The following is a description of a gene set: from publication Gavish A, Tyler M, Greenwald AC, Hoefflin R, Simkin D, Tschernichovsky R, Galili Darnell N, Somech E, Barbolin C, Antman T, Kovarsky D, Barrett T, Gonzalez Castro LN, Halder D, Chanoch-Myers R, Laffy J, Mints M, Wider A, Tal R, Spitzer A, Hara T, Raitses-Gurevich M, Stossel C, Golan T, Tirosh A, Suvà ML, Puram SV, Tirosh I (PMID 37258682) Genes upregulated in subsets of cells of a given type within various tumors In this study, an extensive analysis was conducted to define meta-programs (MPs) capturing intra-tumor heterogeneity across a spectrum of tumor types. The approach utilized non-negative matrix factorization (NMF) to analyze each cell type separately within individual tumor samples. This involved the analysis of malignant cells, macrophages, fibroblasts, endothelial cells, epithelial cells, T-cells, and B-cells. NMF was executed with varying parameter values (K=4, 5, 6, 7, 8, 9), thereby generating 39 programs for each cell type per sample. Each NMF program was summarized by the top genes based on NMF coefficients.\nRobust MPs were then delineated for each cell type using a set of stringent criteria, including recurrence within the same tumor, similarity to programs in other tumors, and non-redundancy within a tumor. Subsequently, these robust NMF programs were clustered (per cell type) based on Jaccard similarity, leading to the identification of MPs associated with each cell type.\nTo enhance the quality of the MPs, a refinement steps were undertaken, involving the removal of MPs suspected of reflecting low-quality data (with an overrepresentation of ribosomal proteins or mitochondrial-encoded genes), single-study inclusion, or similarity to miss-annotated cell types. Human Gene Set: GAVISH_3CA_METAPROGRAM_FIBROBLASTS_CAF_8 species: Homo sapiens, and this is the list of marker genes: ANO1, F2R, CLDN11, MMP28, CRIM1, ITGB5, ENG, NTM, SEMA3C, HAND2-AS1, ELN, CDKN2B (NCBI Gene Id 1030), TSHZ2, COMP, INMT, LAMP5, DPEP1, CST2, NFIX, CST1, SERPINE1, IGFBP2, PRELP, PKDCC, FRZB, RAMP1, RFTN1, IGFBP5, NR2F1, STRA6, MATN3, CADPS, PPP1R14A, TNS1, NT5DC2, CXCL14, IGFBP3, ITGBL1, MEST, COL10A1, CYP1B1, ZCCHC24, LTBP2, CD248, LRRC32, EGR2, SLC6A6, COL16A1, ECRG4, CDC42EP3 (NCBI Gene Id 10602)